The following is a description of a gene set: part of: Mitotic Anaphase species: Mus musculus This event has been computationally inferred from an event that has been demonstrated in another species.<p>The inference is based on the homology mapping from PANTHER. Briefly, reactions for which all involved PhysicalEntities (in input, output and catalyst) have a mapped orthologue/paralogue (for complexes at least 75% of components must have a mapping) are inferred to the other species. electronically inferred by orthology from the curated human pathway Reactome Pathway: Nuclear Envelope (NE) Reassembly, and this is the list of marker genes: Vrk1 (vaccinia related kinase 1), Ppp2r2a, Seh1l, Cdk1, Tuba1b, Lmnb1, Nup85, Tuba8, Tubb6, Cc2d1b, Tubb4a, Vrk2, Tuba3b, Ccnb1, Tubb4b, Ran (NCBI Gene Id 19384), Kpnb1, Lbr, Tuba4a, Ankle2 (NCBI Gene Id 71782), Nup155, Nup93, Tuba1c, Nup133, Ndc1, Sumo1, Nup205, Ist1, Tubb2b, Chmp2a, Tubal3, Tuba1a, Chmp2b, Lmna, Emd